The following is a description of a gene set: studied in species Mus musculus Mouse Gene Set: GOBP_RESPONSE_TO_BACTERIUM Any process that results in a change in state or activity of a cell or an organism (in terms of movement, secretion, enzyme production, gene expression, etc.) as a result of a stimulus from a bacterium., and this is the list of marker genes: Vgf, Mir467d, Myo1f, Gsta1, Defb30, Trf, Rnase9, Wfdc11 (NCBI Gene Id 629761), AA467197, Lyzl4 (NCBI Gene Id 69032), Ctsg, Ifit3, Cd24a, Defb6, Mr1, Mapk1, Cactin (cactin, spliceosome C complex subunit), Oas1c, Vil1, Cxcl10, Lcn10, Cyp1a1, Rasgrp4, Trim41, Mir342, Selenos, Oas1e, Snord3a (NCBI Gene Id 19850), Srr (NCBI Gene Id 27364), Ankrd1, Wfdc5, Nkx2-1, C4bp, Peli3, Defb36, Gbp6, Mir181a-1, Gm25038, Chd7, Trav8d-1, Bpifa2, Tusc2, Ass1, Mir700, Gbp2, Tspo, Ren1, Fzd5, Tjp1, Ccr5, Mir383, Camp, Mir431, Nfkbia, Serpina3f, Mir21a, Cyp27b1, Mir20a, Il36a, Gas2l3, Mecom, Ang6, Gpr15lg, Lsm5, Ces1c, Dhx58, Prdx3, H2-M3, Scimp, Mir210, Clps, Fmo1, Il23r, Defb48, Mir139, Mir106b, Scnn1b, Trac, Mir182, Foxp3, Cxcl2, Rpl13a, Mir181b-2, Mir497, Mt2 (NCBI Gene Id 17750), Tnip2, Saa3, Adamts5, Bpifa1 (BPI fold containing family A, member 1), Rdh18-ps, Bcl3, Ptger4 (NCBI Gene Id 19219), Ptger2, Defa37, Penk, Dgkb, Gja1, Spi1, Ptger3, Raet1d, Defa24, Defb18, Cited1, Ly86, Wap, Sgms1, Irak4, Prpf8, Fos, Casp7, Adgrl2, Tmem255a, Pcyox1l, Mirlet7g, Hp, Fosl2, Cr2, Ikbip, Ces1g, Cnp, Fgf10, Bpi, Scn7a, Src, Il10, Gsta2, Gata1, Mir10a (NCBI Gene Id 723893), Il12rb2, Wfdc10, Klk5, Defb4, Atp4b, Trav3-1, Adh5, Cd160, Hba-a2, Ppard (NCBI Gene Id 69050), Adm, Trav8n-2, Havcr1, Dao, Prkd1, Gas5, Snx3, Stab1, Defa40, Gm14335, Defb20, Defa34, Klhl6, Gsdmc4, Wfdc3, Ighg2b, Mir350, Mir301, F2r, Cyba, Trim30b, Alpk1, Slc22a21, Prdx2, Mir486, Cd14, Bin1, Foxp1, Prkcd, Pycard, Dusp10, Unc13b, Trav3-4, Defb2, Ppbp, Gbp4, Mir146, Nos2, Eif2ak2, Wfdc16, Ednra, Plscr2, Tlr1, Scarb1, Cd36, Bcl10, Wfdc9, Defb37, Igkv6-14, Mir19b-1, Cd4, Chmp5, Mlh1, Mir323, Slc15a2, Enpp1, Serpina3n, Mir29b-2, Ccdc80, Lyzl6, Casp9, Btk, Tnfsf4, Pck1, Mir26b, Myd88, Mapkbp1, Alpl, Mir133b, Slc9a9, Pla2g6, Rnf213, Grn, Tbxa2r, Mir193a, Defb43, Ppm1d, Mir433, Mapk8, Notch1, Defa41, Stab2, Nlrc3, Selenof, Cflar, Cldn3, Mir202, Palm3, Gbp8, Ikzf3 (IKAROS family zinc finger 3), Malt1, Sp110, Pglyrp3, Gsdmd, Mir16-1, Defb35, Nr1i2, Psmb9, Hadhb, Defa3, Trav8-1, Rps19, Gsdmc3, Mir223, Itgav, Rnase2a, Rps6kb1, Pfpl, Muc19, Il1a, Wfdc2, Bnip3, Irf8, Mir148a, Fer1l6, Defb14, Lypd8, Mir30c-1, Nos1, Aicda, Irak3, Rarres2, Casp4, Ang4, Ly96, Jchain, Herc6, Npy, Hsf1, Il10ra, Ptpn11, Cxcl9, Mirlet7a-1, Ifi205, Cd274, Gbp10, Ppp1r11, Naip1 (NLR family, apoptosis inhibitory protein 1), Mir106a, Fbxo3, Gfi1, Epha2, Ncl, Plaat3, Mgst2, Gpx1, S100a8, Pglyrp1, Serpine1, Plac8, Cyp3a41b, Ear2, Cldn1, B2m, Mir122, Sirpa, Tlr4, Fga, Cyrib, Mapkapk3, Ahr, Fpr-rs4, Zfp983, Oas2, Cfd, Plaa, Tifab, Inava, Mir103-2, Ikbkg, Tab3, Mir7b, Klk7, Drosha, Mir26a-1, Rnase12, Tnfaip8, Pabpn1, Defb33, Gpx4, Defb12, Slfn2, Igkv2-137, Lta, Tlr2, Dhx15, Tlr9, Zp3r, Ccr7, Mir500, Trav3d-3, Hamp, Cd52, Akirin2, Il1f10, Trim30d, Upf1, Mir217, Hck, Nos3, Mir30a, Cyp2b10, Jak2, Abca1, Slc30a1, Tmf1, Irgm1, Cst11, Mir15b, Kyat1, Wasl, Ccl2, Ido1, Cxcl16, Defb25, Tbk1, Acp5, Hnrnpa0, Cyp3a11 (NCBI Gene Id 13112), Rnase6, Emilin1, Eppin, Havcr2, Bpifa5, Lpo, Mgst1, Mbl2, Cav1, Cfh, Ccl28, Bcr, Trim5, Rab1a (RAB1A, member RAS oncogene family), Defb39 (NCBI Gene Id 360214), Cfb, AY761185, Cnr1, Mirlet7i, Mir29a, Tnfaip3 (NCBI Gene Id 21929), Ptafr, Mir421, Rnase4, Fcer1g, Naip5, Ifna1, Wfdc6a, Stox2, Trem3, Rpl39, Col6a1, Abl1, Hmcn1 (NCBI Gene Id 545370), Fkbp5, Car5b, Mir501, Cd47, Dab2ip, Mir293, Tslp, Hmgcs2, Tgtp1, Ccdc186, Vim, Pla2g1b (phospholipase A2, group IB, pancreas), Defb15, Defb38, St13, Defa39, Slc11a1, Gch1, Irgm2, Fau, Romo1, Mbl1, Lalba, Edn1, Mir15a, Star, Ighg2c, Trav21-dv12, Il27, Rgs1, Epo, Rab7, Erbin, Defa42, Pygl, Cd79b, Mir200c, Nr1d1 (nuclear receptor subfamily 1, group D, member 1), Mmp8, Fasl, Defb21, Mir181c, Gpr31b, Rnf31, H2bc21, Mir23b, Bmp6, 1500002F19Rik, Casp3, Zfp36 (NCBI Gene Id 22695), Gsdmc2, Mir511, Trav10, Oas1a, Mirlet7b, Resf1, Mir381, Cx3cl1 (NCBI Gene Id 58173), Mir17, Lrg1, Hpgd, Mir374b, Gm12250, Parg, Cdk4, Arid5a, Gstcd, Csf3 (NCBI Gene Id 12985), Znfx1, Plcg2, Defb34, Mir7-1, Cebpb, Trdn, Hmgb1, Defa5, Trav2, Cdk19, Defa26, Spag11a, Il1b, Mir425, Gm24787, Bank1, Tnip3, Adamts13, Rac1, Mir1899, Trem2, Gsdma, Elane, Gkn2, Defa38, Cyp2e1, Reg3b, Ighg3, Axl, Abcb1a, Fcgr1, Ptgs2, Mir30c-2, Defb46, Wfdc17, Ripk2, Nlrp1a, Igha, C3, Wfdc18, Rbck1 (NCBI Gene Id 99156), Oas1d, Trav3-3, Mir24-1, Bdkrb1, Defb41, Il36g, Cd209d, Stap1, Trem1, Defa17, Mir144, Ifng, Ifi204, Pla2g2a, Abr, Gstm3, Defb50, App, Ppnr (NCBI Gene Id 26930), Mir409, Lgals9, Trav10n, Mir142, Mir29b-1, Fam20a, Ear10, Akap12, Xbp1, Snca, Mir26a-2 (NCBI Gene Id 723962), Slc22a5, Cebpe, Fgb, Tab2, Adam17, Defa29, Cyp3a25, Nfkbib, Slc17a5, Colec12, Mif, Ear1, Ace, Gbp7, Tnfrsf1b, Glycam1, Nod2, Pgc, Rhoa, Scd1, Mir184 (NCBI Gene Id 387179), Nfkb2, Ggt1, Pnliprp2, Mir155, Lyz2, H2-K1, Adam9, Mir107, Fpr-rs6, Macrod2, Galp, Rnase10, Prlr, Nfib, Esr2, Acod1, Defa2, Akap8, Il18, Tnf, E2f1, Zc3h12a, Cx3cr1, Gfer, Sash1 (NCBI Gene Id 70097), Isg15, Capn2, Rnase2b, Trim30a (NCBI Gene Id 20128), Mavs, Aqp1, Cd86 (CD86 antigen), Defa21 (NCBI Gene Id 66298), Cd180 (NCBI Gene Id 268699), Prg2, Wnt5a, Rab14, Hmgb2, Iigp1, Slamf8, Mill1, Cd209b, Fabp4, Defb1, Reg3g, Nr2c2, Slamf9, Ifit1, Defb10, Prkca, Gm6040, Wfdc21, Map3k7, Adamts4, Ccr4, Sprr2a1, Ticam1, Thrsp, Pisd-ps1, Trav8d-2, Leap2, Nlrc5, Gpc3, Chga, Mir140, Nlrp10, Ncf2, Noct, Cd80, Trim6, Wdr83, Arg2, Mir205, Pde4b, Tlr11, Ctr9, Naip2, Tap2, Trim30c, Defb47, Tfap2a, Tent5a, Mpeg1, Ccl27a, Muc5b, Nexn, Lyg1, Gsdma2, Defb11, Cd300lb, Xiap, Mir494, Trim12a, Gsdma3, Naglu, Trib1 (tribbles pseudokinase 1), Lyst, Mir27a, Umod, Mmrn2, Ighe, Lbp, Ptgfr, Rpl30, Mir215, Mir451a, Mapk3, Tut4, Plscr1, Irf5, Fgr, C2, Thbd, Ear6, Oas1g, Il36b, Mir27b, Litaf, Ppl, Pde4d, Ifi44, Saa1, Ceacam20, Casp1, Clec4e, Nr1h3, Snhg1, Mir133a-1, Tfeb, Cnr2 (NCBI Gene Id 12802), Serpinb9, Il12a, Lypd8l, Ephb2, Cubn (cubilin), Prkce (protein kinase C, epsilon), Mir331, Mir199a-1, P2rx7 (purinergic receptor P2X, ligand-gated ion channel, 7, NCBI Gene Id 18439), Ang, Defb29, Rab29, Mir146b, Ednrb, BC018473, Mtdh, Shc1, Fcgr2b, Nr4a1, Nuggc (NCBI Gene Id 637464), Lyz3, Ivl, Ncf1, Zg16, Nfkb1, Igkj1, Mx2, Defa25, Evpl, Stat5b, Mir30e, Emilin2, Trim12c, Ms4a1, Mir200b, Gjb2, Ifne (NCBI Gene Id 230405), Ticam2, Cdc73, Mir199a-2, Mir194-2, Bmp2, Mir125a (NCBI Gene Id 387235), Lrat, Trav11, Lcn2, Ugt1a1, Tlr6, Adipor2, Smad6, Marchf2, Amy1, Gzma, Slpi, Fuca2, Scgb1a1, Mir30d, Gbp3 (NCBI Gene Id 99898), Gm23054, Lyz1, Mrc1, Slco1b2, Mir192, Trav5-1, Rnase11, Ighm, Pdcd1lg2, Irak1, Mir24-2, Defa35, Defa28, Ear14, Tnfsf8, Defb22, Ang2, Mir30b, Adgrb1, Il12b, Mir98, Naip6, Ogt, Abcd2 (NCBI Gene Id 26874), Ttc39aos1, Pf4, Adh7 (alcohol dehydrogenase 7 (class IV), mu or sigma polypeptide), Gzmb, 1810065E05Rik, Ltf (lactotransferrin), Mirlet7d, F2rl1, Cd84, Efnb2, Stat1, Spon2, Nlrp6, Th, Gm22053, Card9, Spag11b, Ptger1, Mir7-2, Gbp2b, Gimap6, Tcf3, Ly6a, Rps6ka3, Vip, Cxcl13, Hamp2, Rag2, Otud5, Ifnar1, Mir181a-2, Lgals4, Epsti1, Gsdmc, Ly6g6c, Cps1, Paf1, B3galt5, Defb8, Ptgir, Mir291b, Ifnb1, Lias, Pglyrp4, Oas3, Fgf15, Ppm1e, Il6 (interleukin 6), Mir133a-2, Mapk14, Alad, Fcer2a, Nfkbiz, Gjb6, Adipoq, Akt1 (thymoma viral proto-oncogene 1), Defb5, Tnfrsf14, Cyp3a41a, Defa22, Nfkbil1, Rab34, Vegfd, Rela, Defb42, Mir147, Irak2, S100a14, Ldoc1, Mir744, Trav5-4, Lyn (LYN proto-oncogene, Src family tyrosine kinase), Lyg2, Wfdc15b, Wfdc12, Shpk, Defb9, Nod1, Rnase13, Mpo, Cxcl15 (C-X-C motif chemokine ligand 15), Mapkapk2, Il7r, Dmbt1, Mir18, Oas1h, Ghsr, Tac1, Mir194-1, Krt6a, Pdcd4, Map2k3, Pde2a, Mir672, Cd96, Mir19b-2, Seh1l, Maob (NCBI Gene Id 236712), Map2k7, Mir16-2, Tmem229b, Selenow, Defa30, Mef2c, Adamts9, Cd6, Inhca, Syt11, Pmp22, Nr1h4, Tirap, Ankrd17, Car3, Rbpj, H2-T23, Mirlet7a-2, Tnnt2, Defa20, Rnase1 (NCBI Gene Id 19752), Cep192, Il17a (NCBI Gene Id 16171), Cd68, Sprr2a3, Blvra, Kmo, Sharpin, Nlrc4, Anxa3, Defb40, Fpr2, Defa31, Oas1b, Defb7, Sod2, Fpr-rs3, Cd55, Fpr-rs7, Naaladl2, Sbno2, Defb13, Trim55, Fcgr4, Kcnj8, Mir150, Nlrp3, Il36rn, Gbp9, Pten, Cmpk2, Il23a, Nqo1, Mir224, Lilrb4a, Pcsk1, Reg4, Rara, Il33, Ighg1 (NCBI Gene Id 16017), Slc12a2, Epx, Extl3, Pglyrp2, F2, Cd55b, Hba-a1, Ptpn6, Optn, Irf3, Plscr4, Peli1 (NCBI Gene Id 77964), Slc10a2, Rnf5, Upk1b, Tnip1, Clec4d, Defa23, Defb3, Mir126a, Trav5d-4, H2bc12, Plscr3, Pld1, Wfdc13, Mmp7, Oas1f, Syk, Notch2, Wfdc15a, Il27ra, Nagk, Fer, Igtp, Ptpn22, Gbp5, Mir345, C5ar1 (NCBI Gene Id 12273), Trpv4, Mir598 (microRNA 598), Tnfrsf11a, Mir103-1, Git1, Ang5, Abcc1, Cxcl5, Spn, Lpl, Usp18, Gpx2, Il17f, Defb19, Traf6, Slfn4, Ociad2, Slc7a5, Letmd1, Klrk1 (killer cell lectin-like receptor subfamily K, member 1), Retnlb, Gpm6a, Ssc5d, Tnfrsf1a, Gstp1, Il22ra1, Mir484